Given this list of marker genes FOXG1-AS1, EPB42, RAPGEF3, RPS6P23, CHKA, ITGA7, ZNF331, ENSG00000254675, NPHP4, GALNT7, DCK, LINC02420 (long intergenic non-protein coding RNA 2420), UBE2J2, GTF3C2-AS1, OFD1, SARS1, PTPRF, WT1, NR4A1, NAPRT, DENND1C, FAM178B, PSD, NME9, TEX29, F10-AS1, C2orf69P2, AUP1, DHRS1, ENTR1P1, CADM2, LEFTY1, GREP1, SMIM12, DLGAP2, UPK1A, ANK1, KIR3DL3, LINC01579, TTC13, PGK1, SH3BGRL3, CSDC2, CDC42BPG, PLPP4 (phospholipid phosphatase 4), ZDHHC11B, WTAPP2, RYR3-DT, CES3, STPG3-AS1, PPFIA4, CARMIL2P1, ATAD3C, JUP, ACSL6, TTTY14, MUC20, RAX, MTA1, CTSB, GSDMB, CCL26, NIPAL3, AMPD3, PKP4, MIR34AHG, BCL7B, LAGE3P1, GID4, GPSM1, CLSTN3, PPP1R9A, ADCY3, PLPP3, ABCA2, MOB2, LINC01165, CSAD, KCTD10, PIEZO1-AS1, IGSF22-AS1, HECTD3, MYOM2, CIZ1, HMGA1P5, MTNAP1, PGD, EEF1A1P7, ARF4P1, ABCC8, SCUBE2, CCNYL2, DEFA7P, DNAAF5, LIN37, MSRB3, PDCD5P2, CLPTM1, PIK3R1, PCIF1, DHRS11, VPS51, MIR4300HG, ENSG00000188897, SCGB1B2P, SLC25A10, ATG13, ACOX3, SLC26A9, LINC02641, TNFAIP3, SPATA20, PFKP, FJX1, PA2G4P5, LAMB2P1, ARHGAP40, DYNC1H1, PRKCD, NXPH3, CAMSAP1, LINC02806, CHRNA2, VPS4A, KLHL17, DLD, PLA2G6, CACTIN, SLC6A16, LINC01104, DNALI1, LINC03021, EPHA10, LMF1, UGT3A2, NRAS (NRAS proto-oncogene, GTPase), PYROXD2, PPP1R2P5, VSIG10, LRRK1, MIR7843, CYP2F1, RPL23AP89, MBD1, ACYP2, SMIM47, TIMM21, ADSS1, TRAPPC9, LETM1, LY6G5C, TPRG1, B4GALNT1, VDR, SFRP4 (secreted frizzled related protein 4), NBEAP4, DPP9, MMP2, WDFY4, ANO7L1, DLG5, ASTN2, TNK1, GTF2IRD1, MVP, DNAH9, MGAT4B, GOT2P2, KCP, ZNF827, CEACAM21, TEX264, EBF4, AOPEP, SARM1, YWHABP2, PPP2R1A, EIF4A2P1, NFE2L1, PI16, RPS27P14, PNPLA7, ANTKMT, SLC9A2, FANCD2OS (FANCD2 opposite strand), DIRAS1, PC, CSGALNACT1, TSPOAP1, RPL37A-DT, RAB11FIP4, RBM44, TEP1, PAQR6, FOXN3, DBN1, TASOR, GRASLND, EVI5L, CACNA1A, FBXO17, DGKG, SLC2A8, PINK1, PHF8, HSPB8, MIR9-1HG, CDIP1, SF3A1, TMEM132D-AS1 (NCBI Gene Id 283352), BMF, RAB11FIP5, GNMT, ABCC11, STK11IP, ST6GALNAC1, PTPRD, PIK3R2, PPP1R16B, MED15, AQP5, PPM1L, PRKCG, BCAS3, EMC10, DAP3, PRKCZ, ABCC5, CATSPER2, GAS2L1P2, CYMP-AS1, PRLHR, SMURF2P1, PIDD1, ZIC4, CEACAM7, DPEP1 (dipeptidase 1), LDLRAD4 (low density lipoprotein receptor class A domain containing 4), CD33, KALRN, JPH3, NDUFV2P1, KIRREL3, U2AF2, B4GALNT4, POLE, CECR2, ARHGAP44, GRM1, NLRX1, HIKESHI, KRT125P (keratin 125, pseudogene), AP2A2 (adaptor related protein complex 2 subunit alpha 2), FBXO24, HDGFL1, PRSS44P, ENSG00000223343, ZFP14, HERC2, RUFY1, ANO10, MIR100HG, RUVBL2, PIGG, GCN1, STARD3, CCAR2, GALNT9, GPR162, GABBR2, MIR6807, ECH1, VCF1, APP, PYDC1, DAAM2-AS1, DDX51, GFI1, HYAL2, ENSG00000246090, PRKCB, ENSG00000231964, POLR3A, ABHD17AP6, DDR1, PTPRN2-AS1, BIVM, GRK1, MPPE1, RPAP2 (NCBI Gene Id 79871), MYO1F, PACS2, ENSG00000267053, SORCS2, FTH1P1, SMPD2, ARHGAP27, MAPK10, BSN-AS1, PSTPIP1, FBXW4, KCNJ9, AKIRIN2, GPR139, BEST4, TOPAZ1, DLEC1, CEACAM5, CTSL3P, SYCP2, TMEM178B, POLD3, PLXND1, ARHGEF1, MEGF11, AEN, NPM2, ARHGEF11, IGHJ5, ARAP1, AATK (apoptosis associated tyrosine kinase), KIF1A, MIR4436A, OR7E94P (olfactory receptor family 7 subfamily E member 94 pseudogene), TFAP2E-AS1, SLC39A13-AS1, MFSD11, CDH16, LINC01725, RYR3, SLC15A1, ADCY5, PRSS48, MLC1, DNAJC4, TRPV1, WDSUB1 (NCBI Gene Id 151525), RPL37A, ACTG1P16, GLIS3, IFRD2, EIF2AP4, RARRES2P9, CPA1, MRPS6P2, TTYH2, IGHJ3P, ABTB3, ASTN2-AS1, TM4SF19-DYNLT2B, ATP1A2, BANP, RPL23AP65, AQP5-AS1, E2F3P2, ST7, POR, NRBF2P2, EMC1, PRKCZ-AS1, RBFOX3, FAT3, ZNF320, GGCTP1, AOC1, THPO, HOXB3, LEFTY3P, KLHL5P1, LOXL2, ENOSF1, ALDH1L1, EML6, JDP2, PLXNB3-AS1, KLHDC4, LINC01606, ESPL1, FLJ16779, SSTR5, HIRIP3, IL5, AMPD2, ENO3, NEURL4, NEU4, PIK3R6, NPL, FLOT2, ABLIM2, NUDT9P1, CCDC57, TMCO3, IGHD4-23, GDNF, KRT4, GLIPR2 (GLI pathogenesis related 2), MIR6072, LIMD1, SEC14L6, B4GALT7, SPTAN1 (NCBI Gene Id 6709), ARAP1-AS1, PPIL6, ANKH (ANKH inorganic pyrophosphate transport regulator), SPSB4, LMNB2, SLC19A1, MYO7B, TTC6, MTHFSD, DSCC1, MEG8, ENSG00000246308, SUPT5H, FIGLAP1, KISS1 (KiSS-1 metastasis suppressor), BPI, CARD9, USP38-DT, LINC00454, SH2D3C, NRXN1, NEK8, FAM3B, CYTL1, NYAP1, ARHGEF12, SYTL1, LINC02609, MICU2, MYH11, STPG1, DMAP1, PANX3, TMEM109 (NCBI Gene Id 79073), MIR589, KAT5, MFHAS1, SCGB2A1, MN1, WASL-DT, RPL15P18, ANKRD33BP5, C20orf204, LRG1, PTPN23, SSBP3P5, CDC20-DT, NEB, GAPDHP58, PIP5KL1, CUL9, ZNF619, MDGA1, CLPSL1, NPC1L1, C11orf98P3, PHF2P2, GAD1, USP20, TTC41P, DNM1, RBCK1, ZDHHC8BP, CTBP2P4, WDR90, TP53TG3GP, CROCCP3, GGA3 (NCBI Gene Id 23163), MRO, KRT18P61, CYP2D6, CROCC, SH3TC1, MIR3137, STMN3, CDC20, PCNX1, PUDPP1, HLA-B, FGFR1, LRIG1, ZNF469, HNRNPM, CHL1, DENND5A, KRT73-AS1, XRCC3, TRMT2A, BMAL1, CNNM3, TGFA, LINC01088, KRT79, RIPOR1, HPCAL1, TRIM7-AS1, TGFB1, PCBP4, KIF19, MEG9, LIPT2, KIRREL3-AS3, PPP1R14D, GLI2, MSN, C11orf21, KRBA1, TTC39A-AS1, CRB3P1, FRG1GP, CEP250, POLR3E, MAD1L1, LARP1 (La ribonucleoprotein 1, translational regulator), CAPN14, KMT2E, TSPAN32, GON4L, SLC9A1, FADS6, PARVG, SEC61G-DT, RALBP1, KRTAP12-5P, SLC35G1, FLNA, KSR1, POLG, GPER1, MROH7 (maestro heat like repeat family member 7), ANKRD26P4, SART1, AGPAT3, ADAM12, JDP2-AS1, CBX7, SIGIRR, FOXP2, HRAS, PRDM13 (PR/SET domain 13), SCAT1, ARHGAP23, PDK4-AS1, LENG8, NELFCD, LRCH3, ZDHHC1P1, BCAN, GSG1L2, MEIS1, SNAP47, DYNC2I1, MGRN1, SNX29, SPTBN5, ADCY8, PDGFRB, WNT5A, FAIM2, ENTPD2, KIF18B, ADAD1, FTMT, PBK, CHODL, P4HTM, SLC6A1-AS1, CHORDC1P1, KRT17P3, MUS81, FGFR3P3, TKT, ACOX2, RETREG1, RPL31P2, GAK, KCNIP4, PPP1R3B, CLN8-AS1, WRAP53, UNC13D, TNKS2-DT, PRRT1, WBP2NL, MAGOH-DT, CYP4F2, TLCD3A, ENAH, PARVA, PRKAR1B-AS2, ARL2, PDIA3P2, SFRP5, GLCCI1, ACP7, PAEPP1, SIGLEC6, BCL3, CNN3P1, AKT1S1, TP53TG3HP, EXOSC8P1, MAN1A2, ABHD17A, NOL4L-DT, IGHD1-1, WIPF1, TM4SF19, CTU2, NEFHP2, DEPDC5, FLNB-AS1, CRMP1, ATM, GLP2R, NISCH, TRIM5, RPH3AL, GLYATL1, MYO1H, IPO4, TPD52L3, RNU6-797P, KCNIP3, ENSG00000224865, CNDP1, RRP1, PHF24, CXCL2, EYA2, ITM2C, AP5S1, PHLDB3, CABIN1, CIRBP, LCNL1, RNA5SP196, LINC02357, PFKFB2, PRMT3, SPECC1, MYO9B, NCKAP5, ENSG00000225032, RNA5SP215, DCAF8, NKAIN4, SRRM3, SLC7A6, AHNAK2, FARP1, CNN2P9, KRT5, TAF4, SLC38A8, TRAF6P1, TEX14BP, ERBB2, ZNF276, MTDHP2, TOLLIP, ARPIN-AP3S2, TCAIM, RETSAT, CINP, MBTPS1, UNC93B7, TBC1D10C, ANKS1A, MAN2A2, MTND4P12, PPP1R27, LILRB2, BTBD2, COL19A1, SELENBP1, UPB1, EXTL2, MBD3L1, LIG3, URGCP, GPR78, SCART1, CAPN1, ZSWIM8, UCK1, NR5A1, TRPC6, VEPH1, MAP1S, SPEG (striated muscle enriched protein kinase), RGL2, OLFM2, KLHL7 (kelch like family member 7), CHEK2P2, ALG9, CRHBP, TOP1MT, LAMC2, ST14, MGST3, ADCY7, EPS8L3 (EPS8 signaling adaptor L3), LINC00841, HMCN2, C9orf78, ARHGEF2, FLNB, CD82, STH, LINC00904, PPM1H, BEAN1, FBLN2, WSCD1, LHX3, DUSP22, TYK2, PLEKHG3, ZSCAN12P1, LENEP, TGS1, MROH1, RAB43, ADGRA1-AS1, MAP3K11 (mitogen-activated protein kinase kinase kinase 11), IQSEC3P1, SSUH2, MESTP1, PLD3, RNASEH2C, TEAD2, UNC13A, IGSF9B, TBC1D8, MIR33A, UBXN2AP1, ITGB5-AS1, ASCC1, GALNT6, PRCD, LIPE, PPP2R2DP1, GRM6, ADAMTS18, MIR4695, B4GALNT3, GALNT10, EPPK1, TRGV8, THAP3P1 (NCBI Gene Id 100129138), BEGAIN, ID2-AS1, CYP4F22, SMOX, ENSG00000230725, CACFD1, ACTBP8, RECQL4, RNH1, CPNE2, ARMC5, TRIM54, RAB35, ERGIC3, RAPH1, PPM1L-DT, HNRNPH3, CLCNKB, ACSF3, TLE2, SNORD115-8, PLEC, PPP5C, GALNS, USHBP1, FAM53B, MIR6891, CLPS, CRACD, MTND2P28, CYP4F12, ARL5AP4, CABP1, RGS12, RHBDF1, PHF10P2, LINC02532, MCRIP1, OAS3, ENTPD6, FFAR4, DOC2GP, NFKBIA, BORCS8, SMIM24, SLC38A1, MAPK4 (mitogen-activated protein kinase 4), NBPF1, ST13, ENSG00000205414, RWDD2A, YIF1B, PARP10, MAGOH, STARD10, FAM118A, KRT18, EFR3A, YEATS2-AS1, NKAIN1 (NCBI Gene Id 79570), TNS1, PKM, KCTD6, NR2F1-AS1, TTLL10, DNAH17, BICD1P1, SIPA1, TBC1D17, IL12B (NCBI Gene Id 7907), CAPN5, MAN2C1, ADAMTS12, SILC1, SPATA33, MMACHC, TMEM94, DDC, COL20A1, SLC22A2, SPACA1, RBFOX1, GCDH, TBC1D29P, ELAC2, PTGFR, CDKN1A, RDH13, RTEL1-TNFRSF6B, PDCD5P1, FBLIM1, TSSK5P, PASK, MT1G, CHFR, DOK7, CRISPLD2, PLAAT5, ADGRG1, P3H4 (NCBI Gene Id 10609), PITPNM1, MTND1P26, SAXO4, NCAM1-AS1, CAMK2B, SRPRB (SRP receptor subunit beta), PCNPP2, CHRNG, PHLDB1, CLTA, GIT1, BACE1, ENSG00000204684, LINC01837, PDE6B-AS1, RNU6-921P, SNHG32, VAT1, CROCCP2 (NCBI Gene Id 84809), SHKBP1, LINC03028, MIR4665, WDR25, RBM38-AS1, ADH5, UVSSA, AMPH, SFXN5, SLC12A7, AOC4P, LCE1D, NUDT22, DEF8, LINC01273, EXTL1, RASGRP2, LINC01815, CXXC5, TMEM101, PDYN, TTC34, CARTPT, TC2N, ALDH1A3, SNORD115-23, TBCD, PCNT, ESYT1, NOVA2, ATP6V0A4, CTNNB1, MGAT4C, IGHJ6, SMAD9, GNAL, ARRB1, EFCAB2, AGAP1, MFSD12-AS1, SCYL1, SNORD115-16, PVRIG2P, GCNT2, HS3ST4, EXOC7 (exocyst complex component 7), TSEN15P3, RNA5SP452, KEAP1, CCER2, PEPD, TPPP3, KCNH6, PPP2R5C, PICK1, MAPK8, MYO15A, CSNK1G2, NFIB, RAD50, OSBPL5, LINC02682, SYN3, ITPA, DEGS2, STRA6, TRIM3, HCG9P5 (HLA complex group 9 pseudogene 5), MIR623, OSBP2, OR4D2, ATP11B-DT, MYMK, PFN1, RABEP2, TRIM25, NEK2 (NIMA related kinase 2), FIBCD1, ECHDC2, ZDHHC3, NHERF1, RANBP3, PRR14, LINC01961, ZBP1 (NCBI Gene Id 81030), TP53AIP1, RARRES2P8, PRR5L, MBP, TRBV7-9, RPS2P53, BCR, MIR135A1, PLA2G4B, SSNA1, PRKCH, TFDP2, MOG, LINC02644, TLR4, MAPK12, NDRG4, NAGS, COPG1, RNF40, NOTCH1, MIR496, TRGV1, MAB21L4, FAM217B, PYY, CLCN7, PIP5K1C, TRPV4, SNRPGP10, CALCOCO2, RNU6-1105P, ATP6V1B1 (ATPase H+ transporting V1 subunit B1), SH3PXD2B, CAMKK2, FTH1P22, LINC01838, LCN9, ZNF558, CCL15, ARHGAP22, TBX10, HMGN1P32, HSF4 (heat shock transcription factor 4), LEKR1, DSE, SUMF2, RTF2, HSPG2, PIK3R5, POLK, CADM4, SUGP1, PDE1B, HCG22, CTC1, ESRRB, NPRL3, H2AC13, LINC01548, ALPL, P4HA1, CYP24A1, SEZ6, ZNRF1, OR3B1P, C1QC, LINC02664 (NCBI Gene Id 105376481), SLCO2A1, MFSD12, RTEL1, HIP1R, LRWD1, C5orf63, SPTBN2, TYMSOS, TMEM175 (transmembrane protein 175), PSMF1, DDX27, FLYWCH1, FLVCR2, PGLYRP2, CTBP1, FBXL18, RHBDD2, PWWP3A, SNAP47-AS1, SLC51A, ZEB2, TMEM213 (NCBI Gene Id 155006), EIF3B, GAL3ST1, TCF25, MAGEL2 (NCBI Gene Id 54551), SMIM45, ELF3, ATOSB, ME2P1, TMEM26, RIPK3 (receptor interacting serine/threonine kinase 3), ABCA7, CIDEC, PGR-AS1 (NCBI Gene Id 101054525), CSMD1, ANKHD1-DT, CD247, CCDC39-AS1, DBNDD1, ALMS1, PRR5, LINC01565, TIAM1, TFAP2C (transcription factor AP-2 gamma), KRT8, PRTN3, C17orf99, SIGLEC9, PCDHGA8, HTR5BP (NCBI Gene Id 94018), SIAH1P1 (siah E3 ubiquitin protein ligase 1 pseudogene 1), PDE7B-AS1, MCF2L, ATP5MFP1 (ATP synthase membrane subunit f pseudogene 1), FTH1P6, ENSG00000248636, RPF2, KHNYN, CAPN9, USP38, CCDC81, TBC1D31, PAK1, IGSF22, SIL1, DMGDH, BDKRB1, SMOC1, FRG2KP, SVOP, TRA2A, TCEA1P1 (NCBI Gene Id 6918), H3-4, GNAS-AS1, SIDT2, PPP1R16A, MKRN3, NDUFS7, LINC00472, ANKRD30BL, SNORA52, KARS1P2, SHISAL2A (NCBI Gene Id 348378), ILRUNP1, LINC02583, PODN, TRIM15, ARHGEF39, ARHGAP42, PLPPR3, NUDT19P4, MIR4291, KCNC1, RAB26, GNAS, ENGASE, SNORD48, MATR3, JAKMIP1, PDK4, DAO, CEP72, NCOR2, PRORSD1P, LRP1, PPP1R37, FES, PSD4, IGLVIVOR22-1, UCA1-AS1, FBN3, SPAG5, DLEU7, BEAN1-AS1, NPAT, BLCAP, ZNF439, EPHB3, SECTM1, ALOX5, HPS1, DPY19L2P3, DAZAP1, ZNF598, NRXN3, KLK2, RNF6, ZSCAN29, SLC41A3, ABR, CD164, RECQL5, GTPBP1, SLC38A10, CLN8 (CLN8 transmembrane ER and ERGIC protein), MIR6798, RMI2 (NCBI Gene Id 116028), PLK5, PLA2G10CP (phospholipase A2 group XC, pseudogene), KMT2E-AS1, GTF3C2, VGLL3, GPRC5A, ADGRD1-AS1, ELMOD3, FRS2 (fibroblast growth factor receptor substrate 2), ASPSCR1 (ASPSCR1 tether for SLC2A4, UBX domain containing), SH3PXD2A, KLHDC8B, LINC-PINT, TMEM255B, ELAVL3, SH3BP2, ADORA2A-AS1, IFT46, SRSF2, CXXC1, EIF4G2, NOTCH4, SERPINH1, SLC26A10P, CAMK2G, HFM1, ERICH1, RNA5SP19, PNKP, EFEMP2, SOX10, KLHL7-DT, SNRK, ATXN2L, RGS3, ENSG00000275877, PTPN13, NRXN1-DT, PDLIM4, ANKRD6, MST1P2, TIMM44, PPP2R3B, TCF4, ACY3, CASP16P (NCBI Gene Id 197350), FAM99B, GPR108, NEK2-DT, TXNRD2, PCNAP3, PGAP6, DUX4L45, AGPAT4 (NCBI Gene Id 56895), RPLP2, KCNAB2, LINC00567, CORO1B, SHQ1P1, PIEZO1, MUC17, BRPF3, FAM107B, SDC3, DNAI3, EEF2KMT, TTC24, ITGB4, D2HGDH, SFT2D1, NXF1, TCTE1, ENY2, SLC30A7, HDAC7 (NCBI Gene Id 51564), SSU72, ZNF740, IQCE, STAT5B, CHD3, LCE3A, RCN1P2, NIFKP1, HDAC5, NPEPL1, MIR1226 (NCBI Gene Id 100302232), LINC01266, CYP4F11, RNU6-1140P, NT5DC2, SH3GLB2, PCBP3, GPR132, DPY19L2P4, STAT6, SBSPON, LINC02176, BNIP3P1, PRELID1P5, PES1, MPP3, ZNF574, TERB1, ADA2, NXN, RNF220, PPP1R13B, LINC02766, C16orf54, DOK3, CHCHD2P5, AIM2, PLAAT3, MIR6879, LINC02882, NSD1, HPSE2, IGFL2 (IGF like family member 2), SSH3, GYG1P2, MIR6783, LHFPL2, MCHR2-AS1, ATG9B, LINC02611, EPHX1, KCNQ3, COG3, TERF1, NAT16, SLCO4A1, MISP, SEPTIN9, PLK2, ATP2C2, FRS3, NTRK3, BSN, ACTR2P1, PCED1CP, LRRC1, CPSF4L, ZNF556, ELOBP4, OBSCN (NCBI Gene Id 84033), TP53I11, MLYCD, GMDS-DT (GMDS divergent transcript), ATP4A, FBXO15, LINC02980, GHRHR, C10orf95-AS1, SPTSSB, TNK2, TMEM179, MYL5, LRRC32, GCK, LINC02564, ACSL6-AS1, RERE, CARM1 (coactivator associated arginine methyltransferase 1), THOP1, C1orf167, SCRIB, RIC8A, MICALL1, CNDP2, BRF1, TNFRSF8, NFATC1, ANKRD20A19P, MYO15B, MCAM, TAOK2, SUSD4, TPM1, OGFOD3, CSK, PILRB, CALN1, EBF2, CEP170B, LINC02308, LINC02848, here is a description of the gene set: studied in species Homo sapiens Human Gene Set: NFKBIA_TARGET_GENES Genes containing one or more binding sites for (NFKBIA) in their promoter regions (TSS -1000,+100 bp) as identified by GTRD version 20.06 ChIP-seq harmonization. from publication Yevshin I, Sharipov R, Kolmykov S, Kondrakhin Y, Kolpakov F (PMID 30445619)